Given this list of marker genes Rela, Nodal, Gata4, Ptgs2, Brca1, Isl1, Eif2ak3, Sulf2, Bsg, Flt4, Sulf1, Il1b, Adora2b (adenosine A2b receptor), Stat3, Il1a, Cyp1b1, Ccbe1, Hc, C3, Arnt, Nox1, Cxcl17, Hif1a, Rora, Hpse, C5ar1, C3ar1, Il6 (NCBI Gene Id 16193), Atf4, here is a description of the gene set: species: Mus musculus Mouse Gene Set: GOBP_POSITIVE_REGULATION_OF_VASCULAR_ENDOTHELIAL_GROWTH_FACTOR_PRODUCTION Any process that increases or activates the frequency, rate, or extent of production of vascular endothelial growth factor.